Given this list of marker genes UNC13A, RAB3A, SNAP25, UNC13B, STXBP2, STXBP3, SYT4, STXBP1, here is a description of the gene set: species: Homo sapiens Human Gene Set: GOBP_NEURONAL_DENSE_CORE_VESICLE_EXOCYTOSIS The secretion of molecules (e.g. neuropeptides, insulin-related peptides or neuromodulators such as serotonin and dopamine) contained within a neuronal dense core vesicle by fusion of the granule with the plasma membrane of a neuron in response to increased cytosolic calcium levels.